Given this list of marker genes PARG, POLB, LIG3, POLL, PNKP (polynucleotide kinase 3'-phosphatase), POLD1, PCNA, NEIL1, APEX1, ADPRS, POLE, LIG1, POLG (NCBI Gene Id 5428), FEN1, here is a description of the gene set: Human Gene Set: GOBP_BASE_EXCISION_REPAIR_GAP_FILLING Repair of the damaged strand by the combined action of an apurinic endouclease that degrades a few bases on the damaged strand and a polymerase that synthesizes a 'patch' in the 5' to 3' direction, using the undamaged strand as a template. species: Homo sapiens